Given this list of marker genes Psmc6, Psmd8, Uba52rt, Psmd7, Fbxl7, Psmc1, Psma3, Ubb, Psma6, Psmc5, Psmc4, Psma2, Rps27a, Psma1, Psmd3, Cul1, Ubc, Psmd11, Adrm1, Psmc2, Psmd12, Psmb3, Psma5, Psma7, Psmc3, Psmb4, Psmd6, Psmd2, Psmb2, Psmb5, Rbx1, Uba52, Psmb7, Aurka, Psmb1, Psmd14, Fbxl18, Skp1, Psmb6, Psmd13, Psmd1, Psma4, here is a description of the gene set: FBXL7 down-regulates AURKA during mitotic entry and in early mitosis studied in species Mus musculus Mouse Gene Set: REACTOME_FBXL7_DOWN_REGULATES_AURKA_DURING_MITOTIC_ENTRY_AND_IN_EARLY_MITOSIS